Given this list of marker genes ZNF492, AKIRIN2, ZNRF2, GLCE, EPPIN, TTLL5, PF4V1, ARFGEF2, YBX3, COL4A3, IRAK2, DNAJB1, CR1, PIK3CB, CRIPTO, MED13, SOCS2 (NCBI Gene Id 8835), LENG8, KIF21A, RASGRP2, LRRC47, MLIP, PHC3, EEF1AKMT3, TAPT1, GJC1, C5orf22, GSPT1, PAQR3, PRKAR1A, TMEM132B, LPIN2, EVC, VIM, LDAH, HBS1L, MXD1, GNG2, SETDB2, PELI2, CHD5, PARP9, BTRC, ZNF700 (NCBI Gene Id 90592), B4GALT1, PCID2, CD109, SLC25A24, TCFL5, TMEM167A, ORMDL1, ZNF555, ZFHX3, MARCHF5, ADGRF1, ACO1, KLHL12 (kelch like family member 12), MSRB3, AMBRA1, TSNAX, EGLN3, CNTNAP2, PALMD, NSD2 (nuclear receptor binding SET domain protein 2), TFE3, GNPDA2, RALBP1, TMEM45A, EYA3, ACSL6, ATP6V1A, NEUROD1, NFAM1, DCN, PTPN20, RTN4IP1, SELENOP, PTCHD4, CDKAL1, SHISA6, SCN2B, ZHX2, LYRM1, ZIC1, PIK3CA, IL6ST, TMEM182, SCN5A, ICAM1, TMEM70, DHRSX, IL31RA, UBE2R2, MPZ, PYGO1, MTM1, ZNF211, NFIB, MID1, SPOP, CBLB, CAMK4 (NCBI Gene Id 814), ADAMTS5, ITCH, AFG2A, ELOVL7, HIPK2, RAD21, RERE, KLF2, ETV5, ONECUT2, VPS4B, SUDS3, MS4A1, TPP2, SKIL (NCBI Gene Id 6498), MRAS, TRIT1, KDM6A, MRPL15, DCX, CEP170, ACOX1, TANC2, PGR, CHST11, PHLDA1, CDKN2AIP, SNRNP48, EIF5A2, TMPPE, CTSE, CTDSP2, CCER1, RSPO1, CGGBP1, TIAM1, CEMIP2, NCK1, NKRF, CYP51A1, SH3TC2, MTCL2, PRKCB, BTAF1, GOLGA8N, MIER1, AFF4, MAP7, SNX27, BMP8A, DISC1, ZMYND8, KCNN4, AMOT, HOXC10, KCNIP1, SRP9, PHTF2, MBNL2, FAM76A, SLC24A3, LCT, MTX3, SLIT2, WDR48, SRSF9, ZYX, LTBP1, SMARCAD1 (NCBI Gene Id 7303), TCF20, CETN3, PF4, PLXNA4, MRPL20, NDFIP2, PTBP1, NCOA1 (NCBI Gene Id 8648), GAS8 (NCBI Gene Id 2622), SEC24D, KDM4E, ERRFI1, MANSC1, FLRT3, MOB1A, LAIR1, CHST2, TMEM196, CACNB4, TENM1, SLC24A2, ATF7IP, FAT3, AIRIM, G3BP2, CRP, RNF20, TAF12, JADE1, PDE12, NAMPT, C1orf21, RAB20, RFTN2, CEP43, PLPBP, MPEG1, AFF3, POU3F2, PSMA5, ADAT2, SLC39A14, STAT3 (signal transducer and activator of transcription 3), RANBP3L, NDRG1, NUMBL, LNX2, SEMA4D, GALNT2, TP63, ZBTB20, SLC5A12, FBXO9, CEP120, STIM2, UBTD2, SLC4A8, DESI1, CAPRIN1, HHIP, GRIA3, MRPL32, IGSF21, SLC30A4 (NCBI Gene Id 7782), NAP1L1, ZC3H4, SCEL, TAOK1, PIK3C2B, ANTXR1, CREBZF, ATP8B1, IDE, CEP44, MAST4, PNPLA8, SLC11A1, DHX33 (DEAH-box helicase 33), TSC22D1, C6orf62, LHX9, SLC35F1 (solute carrier family 35 member F1), GPR161, NHLRC3, ASB9, CFAP68, CAST (NCBI Gene Id 831), CYTH3, OR51E2, CHCHD3, S1PR3, RELL1 (RELT like 1), RYBP, PLEKHM3, IPO11, IKZF2, CTDSPL, PDILT, IFNLR1, KYAT3 (NCBI Gene Id 56267), ERP29, ABCA12, GPD1, GPM6B, CD34, RALGAPB, KDM5B (NCBI Gene Id 10765), NKTR, RNF8, C11orf87, GFPT1, SOX6, RLIG1, NCOA3, LRP3, KRT2, ZNF451, GNAS, ZNF730, ETS1, ACER3, NCALD, IGF2BP3, ASB7, GULP1, SYT1, ZEB2, IQCB1, TMTC1, AGO2, TMEM220, WDHD1, THEMIS, RASAL2, PHIP, TMEM8B, LRRTM3, MAP1B, ZNF396 (zinc finger protein 396), RC3H1, here is a description of the gene set: from publication Chen Y, Wang X (PMID 31504780) Genes predicted to be targets of miRBase v22 microRNA hsa-miR-875-3p in miRDB v6.0 with MirTarget v4 prediction scores > 80 (high confidence targets). species: Homo sapiens Human Gene Set: MIR875_3P